The following is a description of a gene set: Mouse Gene Set: WP_GPCRS_CLASS_C_METABOTROPIC_GLUTAMATE_PHEROMONE studied in species Mus musculus GPCRs, class C metabotropic glutamate, pheromone, and this is the list of marker genes: Grm5, Grm4, Grm8, Grm1, Gprc5c, Gabbr1, Casr, Gabbr2, Gprc5b, Grm7, Gprc5d, Grm2, Grm6, Gprc5a, Grm3